The following is a description of a gene set: Human Gene Set: HP_PERIODONTITIS Inflammation of the periodontium. studied in species Homo sapiens Periodontitis, and this is the list of marker genes: C1R, COL3A1, AP3B1, C1S, CXCR4, DKC1, ITGB2, CTSC, MIA3 (NCBI Gene Id 440718), LYST, PARN, GFI1 (growth factor independent 1 transcriptional repressor), NHP2, USB1, PLG, CAT, SLC37A4 (solute carrier family 37 member 4), NOP10, CLPB, CTC1, TYMS, OCRL, TERC, WRAP53, FERMT1, FGF3, TINF2, AEBP1, RTEL1, ELANE, NOTCH2, TCIRG1, NPM1, TERT, SLC35C1, SRP19, GORAB